Given this list of marker genes Grcc10, Dpp4, Grp, Ndufs4, Kcnq3, Kcnq2, Grpr, here is a description of the gene set: studied in species Mus musculus Mouse Gene Set: GOBP_PSYCHOMOTOR_BEHAVIOR The specific behavior of an organism that combines cognitive functions and physical movement. For example, driving a car, throwing a ball, or playing a musical instrument.